Given this list of marker genes IGHV4-39, CD79B, IGKV1-5, PSMD3, IKBKG, IGLV1-51, PSMD2, IGHV3-9, IGLC2, BCL10, MALT1, PIK3CD, PSMA5, IGHV3-33 (immunoglobulin heavy variable 3-33), SEM1, ORAI2, CD79A, SKP1, IGHV, NFKBIA, CARD11, IGKV5-2, VAV1, PSMA7, PSMD14, NRAS, NFKB1, IGLV2-8, REL, IGLV3-25, PSMD8, PSMB2 (NCBI Gene Id 5690), CALM1, BLNK, IGKV1D-12, IGKV2-28, IGHV3-7, IGHV3-23, NFATC2, PTPN6, ORAI1, SH3KBP1, IGKV1-17, IGLC3, KRAS, GRB2, IGKC, IGKV2-29, FBXW11, FKBP1A, IGLV2-14 (immunoglobulin lambda variable 2-14), IGKV2D-30, IGHV3-48, BLK, IKBKB, IGHV4-59, RASGRP1, PSMB5, PSMA3, IGLV1-44, CUL1, IGLV, IGHV4-34, UBB, UBA52, SOS1, IGHV7-81, NFKBIE, PSMD13, ADRM1, NFATC1, IGKV1-33, PSMB6, IGLV7-43, BTK, LYN, HRAS, PLCG2, IGKV3-15, ITPR2, IGHV3-53, PSMD11, PSMC3, STIM1, IGHD, CD19, MAP3K7, PSMD6, PRKCB, PSMB7, ITPR1, IGKV1-12, IGKV1D-33, IGKV3D-20, IGLV1-40, PPIA, IGLV6-57, IGHV1-69, IGHM (immunoglobulin heavy constant mu), IGLV3-1, IGHV3-30, IGLV1-47, IGLC7, IGLC1, IGKV3-20, PSMC6, IGHV1-2, NFATC3, PSMD1, IGHV2-70, PPP3R1, IGHV3-13 (NCBI Gene Id 28449), NFKBIB, PSMB1, IGHV1-46, IGKV3-11, PSMA2, BTRC, PIK3AP1, PSMA4, PIK3R1, IGHV2-5, IGKV2D-28 (immunoglobulin kappa variable 2D-28), PSMC1, IGHV3-11, RELA, PSMC4, IGLV2-11, RASGRP3, PSMB4, PSMA6, TRPC1, UBC, PSMC2, ITPR3, IGKV1-39, IGLV3-21, IGLV3-27, NCK1, PSMB3, PSMD7, CD22, FYN, SYK, IGKV2D-40, PPP3CB, RPS27A, IGKV1-16, PSMA1, IGLV3-19, IGKV1D-16, PSMD12, AHCYL1, IGKV1D-39, CHUK, IGLC6, PPP3CA, IGKV4-1, IGKV2-30 (NCBI Gene Id 28919), IGLV2-23, PSMC5, DAPP1, here is a description of the gene set: Mature B cells express IgM and IgD immunoglobulins which are complexed at the plasma membrane with Ig-alpha (CD79A, MB-1) and Ig-beta (CD79B, B29) to form the B cell receptor (BCR). Binding of antigen to the immunoglobulin activates phosphorylation of immunoreceptor tyrosine-based activation motifs (ITAMs) in the cytoplasmic tails of Ig-alpha and Ig-beta by Src family tyrosine kinases, including LYN, FYN, and BLK.<br>The protein kinase SYK binds the phosphorylated immunoreceptor tyrosine-activated motifs (ITAMs) on the cytoplasmic tails of Ig-alpha (CD79A, MB-1) and Ig-beta (CD79B, B29). The binding causes the activation and autophosphorylation of SYK.<br>Activated SYK and other kinases phosphorylate BLNK (SLP-65), BCAP, and CD19 which serve as scaffolds for the assembly of large complexes, the signalosomes, by recruiting phosphoinositol 3-kinase (PI3K), phospholipase C gamma (predominantly PLC-gamma2 in B cells, Coggeshall et al. 1992), NCK, BAM32, BTK, VAV1, and SHC. The effectors are phosphorylated by SYK and other kinases.<br>PLC-gamma associated with BLNK hydrolyzes phosphatidylinositol-4,5-bisphosphate to yield inositol-1,4,5-trisphosphate (IP3) and diacylglycerol. IP3 binds receptors on the endoplasmic reticulum and causes release of calcium ions from the ER into the cytosol. The depletion of calcium from the ER in turn activates STIM1 to interact with ORAI and TRPC1 channels in the plasma membrane, resulting in an influx of extracellular calcium ions. PI3K associated with BCAP and CD19 phosphorylates phosphatidylinositol 4,5-bisphosphate to yield phosphatidyinositol 3,4,5-trisphosphate.<br>Second messengers (calcium, diacylglycerol, inositol 1,4,5-trisphosphate, and phosphatidylinositol 3,4,5-trisphosphate) trigger signaling pathways: NF-kappaB is activated via protein kinase C beta, RAS is activated via RasGRP proteins, NF-AT is activated via calcineurin, and AKT (PKB) is activated via PDK1. Reactome Pathway: Signaling by the B Cell Receptor (BCR) studied in species Homo sapiens part of: Adaptive Immune System